The following is a description of a gene set: studied in species Mus musculus Mouse Gene Set: GOMF_ATP_DEPENDENT_DNA_DAMAGE_SENSOR_ACTIVITY A molecule that recognises toxic DNA structures, and initiates a signaling response, driven by ATP hydrolysis., and this is the list of marker genes: Rad51d, Msh4, Rad51b, Rad51 (NCBI Gene Id 99282), Msh3, Pms2, Dmc1, Xrcc2, Msh6, Mlh1, Msh2, Rad51c, Xrcc3, Msh5